The following is a description of a gene set: Neoplasm categorized according to type of histological abnormality. studied in species Homo sapiens Neoplasm by histology Human Gene Set: HP_NEOPLASM_BY_HISTOLOGY, and this is the list of marker genes: BMPR1B, MEN1, ACTB, PHF21A, BMPR1A (bone morphogenetic protein receptor type 1A), SPEN, KCNAB2, MAX, ARID1A, PDGFRA, SOX2, DZIP1L, TIAM1, SMAD4, KCNQ1, AURKA, SRY, MDH2, GJC2, FLCN, HACE1, MEG3, KIAA0753, NF2, TMEM127, CTSC, ERCC6, SKI, FAS, PLCD1, CDKN1B, CASZ1, TERT, RPS7, BCL10, MNX1, EP300, PHOX2B, RPL9, DLK1, BRCA2, KIF7, IL6ST, CDKN2B, MAN2C1, SOX5, AAGAB, NOTCH3, CYSLTR2, SDHD, GATA4, NRAS, EXT2, RPS26, CCND1, ERCC4, DKC1, TSR2, TFAP2A, TP53, RPL31, RPL5, UBE4B, HSPG2, MBD4, APC2, NLRP1, CPLANE1, FGFR3, RSPO1, PAX6, RAD54B, RUNX1, PMS1, COL4A6, BUB1, TMEM216, PIEZO1, ALK, PIK3CA, APC, CCM2, TUBB, PDE11A, SEMA4A, ADA2, POT1, ATP6V1B2, CTNNB1, KRT10, FAM20A, USF3, ERBB2, TRIM37, MLH1, PRLR, FH, RPS20, STK11, SLC6A17, FAM149B1, IFNG, TRIM28, RPL35A, NR0B1, MYCN, EXT1, ERCC2, NR4A3, PDGFRB, SLC37A4, DHCR24, TCTN3, RPS19, WWOX, BRIP1, RTL1, RPS15A, GATA1, LRP1, TLR2, LIN28B, OCA2, YY1, SOX9, SLC22A18, ACVR1, FASLG, VHL, RPS28 (ribosomal protein S28), PTPRJ, SOX11, BDNF, TERF2IP, LMNA, RET, RPL18, XPC, TRAF7, MDM2, GPC4, RPS24 (ribosomal protein S24), SMARCD1, ALX4, RECQL4, NR5A1, GPC3, ASCL1, POLH, RPL26, RPS10, ATM, PTCH1, GDF5, LUZP1, FGFR1, GDNF, POLE, KLLN, DHX37, MMP23B (NCBI Gene Id 8510), RAD51D, RAF1 (NCBI Gene Id 5894), SRC, CASP10, MYO1H, EPCAM, ANTXR2, RERE, ANGPT2, RAD51C, RPL8, FOXO1, WT1, KCNH1, KEAP1, ABCA5, CDC73, PRDM16, RNF43, MITF, MAP3K1, GNAS, SMARCA4, LBX1, SMARCC2, FOXC2, MC1R, SOS1, BRAF, RAD50, DDB2, FGF3, SQSTM1, TSC1, MBTPS2, ASPSCR1, KRT1, FLT4, PRKAR1A (protein kinase cAMP-dependent type I regulatory subunit alpha), RPS27, FLNA, RPL11, BARD1, SOX4, CREB1, PAX3, HRAS, CDKN1C, SIX6 (SIX homeobox 6), TOPORS, DPF2, TYMS, DYNC2LI1, KRAS, BLM, MSH2, WRN, RABL3, VPS16, MRE11, IDH1, GCDH, ZFPM2, EWSR1, ZFTA, VAMP7, BRCA1, FAM20C, KRIT1, SKIC3, FIBP, EDN3, PALLD, RSPRY1, CDKN2A, PAX7, NUTM1, KCNN3, TRIP13, MLH3, ANAPC1, RB1, KIF1B, EPHB4, BAX, COL4A5, TYR, TGFBR2, H19, MUTYH, COL14A1, PTPN11 (protein tyrosine phosphatase non-receptor type 11), TAF15, AKT1, SF3B1, SKIC2, CEP57, FLI1, DLST, PRKCZ, MGMT, DCC, NSD1, NF1, MAD1L1, SDHAF2, KIT, CDKN2C (NCBI Gene Id 654235), MAPRE2, CDKN1A, NEK9, PTH1R, CXCR4, SPTBN1, GNAQ, IDH2 (isocitrate dehydrogenase (NADP(+)) 2), SUFU, BUB3, AXIN2, OFD1, GNA11, SEC23B, BAP1, RPL15, POLD1 (DNA polymerase delta 1, catalytic subunit), TRPV3, REST, BUB1B, KCNQ1OT1, MAP2K1, COL1A1, SLC25A11, ELMO2, DLC1, ERCC5, ZEB2, COL17A1, TMEM231, RPS17, ERCC3 (ERCC excision repair 3, TFIIH core complex helicase subunit), RPS29, PDE6D, NBN, IGF2, RPL35, MMP1, BRD4, HEATR3, PALB2, ARID2, PDPN, ACD, RPL27, PDGFRL, SETBP1, ASXL1, GABRD, GLI3, PMS2, SMARCB1, CDK4, C1S, BMPER, KRT17, SMO, PLA2G2A, SDHB, LMO1, TSC2, SDHA, SMARCE1, PDCD10, HDAC4, CHEK2, MSH3, SDHC, GREM1, ARID1B, PDGFB, KANSL1, COL7A1, DIS3L2, POU6F2, PTPN12, RAD51, DICER1, PERP, MTAP, MSH6, XPA, PTEN (phosphatase and tensin homolog), PKHD1, MCC, SPRED1, PTCH2, MVK